Given this list of marker genes TRBV28, HLA-DQB1, MALAT1, TRBV29-1, TRBV7-9 (T cell receptor beta variable 7-9), TRBV20-1, TRBV15, DUSP2, H1-4, here is a description of the gene set: Genes downregulated in CD8 T-cells from Idiopathic Pulmonary Fibrosis Patients vs. Controls Human Gene Set: UNTERMAN_IPF_VS_CTRL_CD8T_DN from publication Unterman A, Zhao AY, Neumark N, Schupp JC, Ahangari F, Cosme C Jr, Sharma P, Flint J, Stein Y, Ryu C, Ishikawa G, Sumida TS, Gomez JL, Herazo-Maya JD, Dela Cruz CS, Herzog EL, Kaminski N (PMID 38717443) studied in species Homo sapiens Thirty-eight PBMC samples from 25 patients with IPF and 13 matched controls yielded 149,564 cells that segregated into 23 subpopulations. Classical monocytes were increased in progressive and stable IPF compared to controls (32.1%, 25.2%, 17.9%, respectively, p<0.05). Total lymphocytes were decreased in IPF vs controls, and in progressive vs stable IPF (52.6% vs 62.6%, p=0.035). Tregs were increased in progressive vs stable IPF (1.8% vs 1.1% of all PBMC, p=0.007), although not different than controls, and may be associated with decreased survival (P=0.009 in Kaplan-Meier analysis; P=0.069 after adjusting for age, sex, and baseline FVC). Flow cytometry analysis confirmed this finding in an independent cohort of IPF patients. Fraction of Tregs out of all T cells was also increased in two cohorts of lung scRNA-seq. CCL22 and CCL18, ligands for CCR4 and CCR8 Treg chemotaxis receptors, were increased in IPF. The single-cell atlas of the peripheral immune system in IPF, reveals an outcome-predictive increase in classical monocytes and Tregs, as well as evidence for a lung-blood immune recruitment axis involving CCL7 (for classical monocytes) and CCL18/CCL22 (for Tregs). (From Abstract)